The following is a description of a gene set: The replication of DNA that precedes meiotic cell division. Mouse Gene Set: GOBP_PREMEIOTIC_DNA_REPLICATION studied in species Mus musculus, and this is the list of marker genes: Mcm3, Mcm2, Mcm5 (minichromosome maintenance complex component 5), Mcm7, Mcm6, Mcm4